Given this list of marker genes CSTF2T, DHRS3, ST6GALNAC2, OR11H4, TCEANC2, NRARP, EPHA7, CHODL, TMSB10, EIF2S1, NFX1, ENKUR, TSHZ1, FRRS1L, NDNF, AVL9, CPSF4L, H3C13, IGDCC3, PRPF38A, DOCK8, CSN1S2AP, CBR1, PDK2, ADH1A, CYRIA, CCDC92B, SLC18B1, GAP43, UBE2L6, ACTA2, PRXL2B, ADAM6, PCDHB5 (protocadherin beta 5), PTPRO, EMB, MPPED2, TRIP11, TMEM59L, MFHAS1 (multifunctional ROCO family signaling regulator 1), SRPK3, MUSTN1, INPP5K, NFYC, CEBPA, TMEM144, ZSWIM7, FLI1, GDPD2, GBP6, REP15, PLP2, THBS1, MGST2, NANOG, UROC1, TSLP, LYRM9, POLQ, CD40, EGFL7, C1QTNF5, ABL1, EPB41, ANP32A, NPVF, C1D, CLMP, UBL3, APP, PSMB11, SF3B6, NOL4L, PDCL, TET1, ANG, ROR2, ADAM8, GPR162, LYVE1, PALLD (NCBI Gene Id 51653), MS4A6A (NCBI Gene Id 64231), TTC34, OPRM1, CCDC187, PTPN5, SYT13, VDR, RSU1, KYAT1, ZBTB47, IRAK4, DAAM2, CYP2F1, OSR2, CLCN5, SLCO6A1, IAH1, PHF14, SNAPC3, RELN, NF1, SUB1, SIX2, SPIRE1, ARHGEF17, PRKG1, IGF1, CYP2A6, TMCO2, PDZK1IP1, EMID1, COG5, UGT2B4, LRRC71, UBL4B, GPALPP1, MSL3B, P2RX5, ANGPT1, CHGB, SPON2, RNF122, UCHL1, LIN7B, RNFT1, DEPP1, ITIH2, LYPD6, TNIP2, SYT11, PGPEP1L, PEG10, TRABD2B, LPIN3, RAB38, NSG1, CFAP119, RAMP3, HSD17B11, KDM5D, CYP1B1, TMED6, TNFRSF25, RBP1, TMEM238L, EGR2, AQP5, UBAP2, CS, BBS7, LRRC8A, FBN2, C3 (NCBI Gene Id 12266), LY6G6C, CHD1L, POU3F2, NCALD, ZBTB1, RAPGEF3, CEL, MGLL, ATP9A (ATPase phospholipid transporting 9A (putative)), ALDH6A1, NIPA1, ASCC1, RHO, ANLN, FIBIN, TMEM53, LRAT, MRGPRF, ST18, NEGR1, ZPBP, MXRA8, NUDT14, ABTB1, LRRC49, SCUBE2, METAP2, DUSP22, CELF4, GRHL3, NDN (necdin, MAGE family member), P2RX6 (NCBI Gene Id 9127), MCU, SESN3, SPARCL1, ST8SIA5, RAI14, CREBRF, UBA6, PDZD11, EBF3, LASP1NB, EYA3, C1QTNF6, B3GNT6, CRMP1, BMF, CTNND2, SLC26A2 (solute carrier family 26 member 2), SORCS1, MMP10, MFRP, SELP, NTF4, AGR2, FOXJ1, UBD, LCE1B, VTA1, NFIB, GABRE (gamma-aminobutyric acid type A receptor subunit epsilon), PRMT7, ZNF670, PAQR5, CCN3, STYXL2, CD48, SYTL2, PHYHD1, KAT6A, SH2D1B, SLC35D3, FOXQ1 (NCBI Gene Id 94234), DHH, DEFB110, ZBTB42, IQUB, ATG7, ARID5B, BAZ2B, GML, GNG4, TTC3, PTPN3, CRTAM, MUC16, IL17RE, AGPS, DOCK10, SH2D5, FBXO32, MAPT, ANKDD1B (ankyrin repeat and death domain containing 1B), here is a description of the gene set: The reciprocal chromosomal translocation t(4;11) is correlated with infant, childhood, adult and therapy-related high-risk acute leukemia. Here, we investigated the biological effects of MLL.AF4, AF4.MLL or the combination of both reciprocal fusion proteins in a conditional in vitro cell culture model system. Several parameters like cell growth, cell cycling capacity, apoptotic behavior and growth transformation were investigated under physiological and stress conditions. Co-transfected cells displayed the highest resistance against apoptotic triggers, cell cycling capacity and loss-of-contact inhibition. These analyses were complemented by gene expression profiling experiments and specific gene signatures were established for each of the three cell lines. Interestingly, co-transfected cells strongly upregulate the homeobox gene Nanog. In combination with Oct4, the Nanog homeoprotein is steering maintenance of pluripotency and self-renewal in embryonic stem cells. Transcription of Nanog and other stem cell factors, like Oct4 and Bmi1, was verified in biopsy material of t(4;11) patient cells which express both reciprocal t(4;11) fusion genes. In conclusion, the presence of both reciprocal MLL fusion proteins confers biological properties known from t(4;11) leukemia, suggesting that each of the two fusion proteins contribute specific properties and, in combination, also synergistic effects to the leukemic phenotype. from publication Gaussmann A, Wenger T, Eberle I, Bursen A, Bracharz S, Herr I, Dingermann T, Marschalek R (PMID 17130830) Up-regulated genes from the set G (Fig. 5a): specific to cells expressing both MLL-AF4 and AF4-MLL fusion proteins. studied in species Mus musculus Human Gene Set: GAUSSMANN_MLL_AF4_FUSION_TARGETS_G_UP